Given this list of marker genes BATF, CCDC74B, TNKS1BP1, ACTRT1, RGS6, LINC01973 (long intergenic non-protein coding RNA 1973), OR2L13, ATP1A3, SLC8A3, DHX57, CHCHD3, MOK, TMIE, SCNM1, ADK, EHD1, GNB2, RFX4, B9D2, IL34, NKX2-1, KCNIP2, TSNAXIP1, NME7, FAM107A, MPP2, CEP135, ODF1, AP1S1, CFAP70, ARHGAP29, GPR162, ANKRD45, C2orf15, CRKL, PPM1E, CCDC181, BTBD3, HSD11B1L, LINC02908, GPR17, PIN1, PHTF1, FXYD1, PER2, EBNA1BP2, PAK4, MICOS13, KCNJ9, GNB4, CAMK1, TAMALIN, CCN3, CADM1, PCF11, BRAF, MET, RTP1, GLRX5, PTK2B, TEX9, TRPS1, PCSK1N, INO80B, CALY, C2orf66, CHD5, PRR3, RREB1, KDM3A, STX8, PTPRR, STX18, WDR47, PUM1, SYT5, BTBD16, TGFB3, ATP13A4, TRMT9B, PRKACA, SLC10A2, IFT22, KMT5C, BDP1, CAMK2A, PBXIP1, CSRNP3, C14orf178, TNKS, CFAP91, L3MBTL2, CRB2, PLEC, TM9SF1, TCTN2, ABHD14A, CEP41, NFATC4, PRRT1, HSDL1, MAPRE3, CDKL2, HMGN2, RNF139, NRSN2, MRPL49, AARSD1, RNF40, LRRC49, TMEM17, BAIAP3, TSGA10, IRS2, TMX4 (NCBI Gene Id 56255), DUSP3 (NCBI Gene Id 284066, dual specificity phosphatase 3), NCALD, AAGAB, RIBC1 (NCBI Gene Id 158787), WFDC3, TTR, CRYZL1, DNAAF1, USP12, SYT6, QTRT1, SPAG16, AGAP2, RNF5, PIH1D2 (NCBI Gene Id 120379), PSD, HDAC4, FOXH1, TTLL1, RHOD, DNAAF11, USF1, STRN4, SLC44A1, STOML2, EDC4, DCDC1, FKRP, DCUN1D4, TP53BP1, ORAI3, BBS1, CNIH2, DHX40, C10orf67, CYRIA, NSMF, ITSN1, NBR2, PRKCG, LRRN3, HNRNPF, PCDHB1, KLHL18, ATL1, TBC1D16 (NCBI Gene Id 54493), SH3GLB2, REM1, MTF1, OSBPL2, UBE2W, LARGE2, GPC3, KCNJ16, HPCAL1, LINC01138, NLGN2 (neuroligin 2), SPEF1, GRIN2D, KATNAL2, E2F1 (NCBI Gene Id 1869), INTS3, THBS3, PPT2, CCSER1, TMED10, ITPR1, ETS2, ZFYVE1, TBATA, TSPYL4, FGD4, POLR3GL, RHOBTB2 (Rho related BTB domain containing 2), ARRDC4, ZP1, MIR137HG, REEP6, ATN1, ITPKA, MINK1, FXYD7, ELMO1, ANKRD13D, RAPGEF3, HPCAL4 (NCBI Gene Id 51440), AP3M2 (NCBI Gene Id 10947), FGF9, QRFP, LYSMD1, DNAJA1, RPL17, MYH2, SAMTOR, ANKFN1, GGNBP2, ZNF532, TUB, DMTN, CDK2AP2, NOS1, TSHZ2, SPARC, KATNAL1, CSTPP1 (NCBI Gene Id 79096), TMEM270, POLL, PHOX2B, PICK1, ENKUR, SEMA4B, DTNA, NIM1K, TMEM67 (transmembrane protein 67), PKIG (cAMP-dependent protein kinase inhibitor gamma), PPP1R17, PHEX, SHANK2-AS3, MAPK10 (mitogen-activated protein kinase 10), MPC2, SPTBN2, SPATA2, CFAP20DC, GRWD1, ATP2B4, ICAM5, CASKIN1, GRM1, DMD, ANK2, E2F3, MGAT4B, FMR1, GAS7, CHL1, EFHD2, NUDC, LAMP5, HYDIN, ZSWIM1, PPP1R21, TUBE1, LINC01567, CINP, UVRAG, ELAVL3, CSMD3, GOLM2, PHC1 (polyhomeotic homolog 1), CFAP52, THNSL1, MPPED2, TUBB4A, EML1, C14orf132, CRIP2 (cysteine rich protein 2), BLZF1, SLC17A6, DAW1, CXXC5, CCDC74A, MAPK11, FXYD6, BAD, ITGB3BP, CFAP57, CIMIP4, PTPDC1, MORN2, YWHAQ, ZNF768, here is a description of the gene set: species: Homo sapiens Genes having at least one occurrence of the motif NNGTNRCNATRGYAACNN in the regions spanning 4 kb centered on their transcription starting sites. This matches the RFX1 transcription factor binding site V$RFX1_02 (v7.4 TRANSFAC). Human Gene Set: RFX1_02